The following is a description of a gene set: species: Homo sapiens The chemical reactions and pathways involving androgens, C19 steroid hormones that can stimulate the development of male sexual characteristics. Human Gene Set: GOBP_ANDROGEN_METABOLIC_PROCESS, and this is the list of marker genes: MED1, HSD17B6, HSD17B3, HSD17B7, SRD5A1, HSD17B4, CYP3A4, HSD17B8, TIPARP, PLEKHA1, WNT4, DHRS9, SGPL1, CYP19A1, CHST10, HSD17B2, INHBA, SPP1, AKR1C4, HSD17B10, HSD17B11, AKR1D1, SRD5A3, ESR1, UGT2B7, CYP17A1, SRD5A2, SHH, HSD3B1, HSD3B2